Given this list of marker genes REG4, PSME2P3, TSPAN8, UGT1A6, MCPH1-AS1, H2BC13, EGF, RCC1, ARHGAP32 (NCBI Gene Id 9743), DUT, TXK, CEP120 (NCBI Gene Id 153241), MMAA, GAS5, SPINK13, ALDH1A2, SEMA3C, LINC02889, NR2F1, MALAT1, SPINK5, CDH17, PLAC8, MARCOL, YAE1, MYBPC1, DSG1-AS1, PTPRO, MLLT3, TM7SF3, DSG3, DMXL2, EPS8, SLTM, LINC00513, here is a description of the gene set: from publication Yevshin I, Sharipov R, Kolmykov S, Kondrakhin Y, Kolpakov F (PMID 30445619) species: Homo sapiens Human Gene Set: CEBPE_TARGET_GENES Genes containing one or more binding sites for (CEBPE) in their promoter regions (TSS -1000,+100 bp) as identified by GTRD version 20.06 ChIP-seq harmonization.